Given this list of marker genes CTPS2, NME1-NME2, ENPP1, ENTPD1, ENTPD3, POLR2D, TK2, POLR1E, TK1, NT5M, RRM1, POLE, POLR1F, POLR2L, TYMS, POLR2C, POLR3G, POLR2A, POLD4, POLD3, DCTPP1, POLR2G, POLR2J, NME1, CTPS1, POLR3A, NME7, POLD1, NME6, POLR1A, POLR2J3, POLR2J2, RRM2, UCKL1, POLR3GL, CAD, POLR2I, NME3, DCTD, UPRT, NME2, POLR2B, CMPK1, UCK1, DTYMK, POLE3, DCK, DPYS, POLA2, ENPP3, DUT, POLR3K, POLD2, POLR3F, POLR3E, POLR1B, POLA1, CMPK2, PRIM2, POLR2H, POLR3B, RRM2B, POLE2, POLR1C, DPYD, POLR3H, UPB1, TYMP, UPP1, POLR1H, POLR1D, POLR2E, POLR3C, UMPS, UCK2, PRIM1, CDA, PNPT1, NT5C, DHODH, NME4, POLE4, POLR2K, POLR3D, here is a description of the gene set: Human Gene Set: WP_PYRIMIDINE_METABOLISM Pyrimidine metabolism studied in species Homo sapiens